Given this list of marker genes PIK3CD, IPMK, PIK3CA, PIK3CG, PIK3CB, PIK3R6, PIK3C2A, here is a description of the gene set: Human Gene Set: GOMF_1_PHOSPHATIDYLINOSITOL_4_5_BISPHOSPHATE_3_KINASE_ACTIVITY species: Homo sapiens Catalysis of the reaction: a 1-phosphatidyl-1D-myo-inositol 4,5-bisphosphate + ATP = a 1-phosphatidyl-1D-myo-inositol 3,4,5-trisphosphate + ADP + H+.